The following is a description of a gene set: from publication Elo LL, Järvenpää H, Tuomela S, Raghav S, Ahlfors H, Laurila K, Gupta B, Lund RJ, Tahvanainen J, Hawkins RD, Oresic M, Lähdesmäki H, Rasool O, Rao KV, Aittokallio T, Lahesmaa R (PMID 20620947) The aim of this dataset was to study in detail the transcription kinetics initiated by cytokine IL-4 in early differentiation of Th2 cells. Human Gene Set: GSE17974_CTRL_VS_ACT_IL4_AND_ANTI_IL12_6H_CD4_TCELL_UP Genes up-regulated in comparison of untreated CD4 T cells at 0 h versus the cells treated with IL4 and anti-IL12 at 6 h. species: Homo sapiens, and this is the list of marker genes: NAP1L5, ENC1, MEF2D, LLGL2, PRKCB, SAXO5, SLC2A3, DIAPH2, MXD1, CAPN2, FAM8A1, PCDH9, RNF139, JUN, BIN2, RASA3, HABP4, TP53INP1, VAMP1, SCARNA17, SNN, GSAP (NCBI Gene Id 54103, gamma-secretase activating protein), ST7L, ZNF34, LINC00955, TTC32, SLC12A7, ARRB2, FAM204A, KRT73, HAR1A, JUNB, SLFNL1, TSC22D1, PXDN, RAP1GAP2, ARRB1, CRAMP1, TENM1, CGRRF1, AHNAK, PDE4D, STK16, FOS, TCEA3, KAT2B, AQP3, ISG20 (interferon stimulated exonuclease gene 20), TBC1D5, PBX4, ZNF669, DENND5A, HSD17B11, AK5, RFX3, UBASH3B, ENSG00000280119, EPHA4, SC5D (NCBI Gene Id 6309), MDS2, ZFAND3, HMGB2, ERP27, GOLGA7B, LINC00896, C16orf54, MXI1, YPEL5 (yippee like 5), PSTK, DNAJB1, MAP4K4, ZFAND2A (NCBI Gene Id 90637), TOB1, KCNA3, PTGS2, VTI1A, MT1X, BEND5, OTULINL, AREG, LRRC37B, TP53INP2, NSMCE3, PDP1, SUSD3, LINC00173, DDIT4, G0S2, GKAP1, SUSD4, DIS3L2, IRS2, ARRDC3, ARHGEF11, KLF4 (KLF transcription factor 4), ITPRIP, BAG3, ADM, MYO1G, ZNF256, TNFAIP3, DUSP1, PTPRM, C16orf74, GADD45A, LPP, ITCH (NCBI Gene Id 83737), FRG1JP, SAMHD1, TRAPPC10, ZNF844, ZBTB25, ZNF731P, SBK1, PYM1, SLC16A5, SYNM, MAFF, PCSK5, PELI2, PBXIP1, FAM117A, NDC80, ENSG00000274253, ZBTB20, C4BPA, TTN, RCSD1, H2AC25, MLLT11, RASGRP2, MARCHF2, AGTPBP1, SMYD3, RETREG1, GGACT, USF3, TAGLN2, SULT1B1, PGAP3, C11orf21, H1-10, CFL2 (cofilin 2), PIK3R5, TSC22D3, ANKDD1A, SKIL, CCDC69 (coiled-coil domain containing 69), GADD45B, DSC1, H1-10-AS1, LDB2, DENND6A, DOK2, EXOC4, EFHC2, OGFRL1, PYHIN1, HAUS3, MORC2-AS1, SYTL2, ADPRM, CD79A, ZFP36L2, PCIF1 (phosphorylated CTD interacting factor 1), DCXR, PARP8, HKDC1, PTP4A1, FHIT, SPINK7, ATXN1L, SIAE, REC8, PERP, RGS2, LINC02223, MARCHF8, ENPP2, TJP2, PLCXD2, SLC22A18, ZNF101, NDRG1, ZDHHC11, ITGB7, H1-2, SIK1, SOCS3, IQGAP2, IRF2BP2, PIEZO1, FHL1, CHD9